The following is a description of a gene set: species: Homo sapiens Bulbar signs Human Gene Set: HP_BULBAR_SIGNS, and this is the list of marker genes: MT-TV, ATXN1, MT-ND3, CACNA1A, MT-TL1, PSAP, MT-TW, GFAP, SLC1A3, RYR1, MT-ND1, ARSA, MT-ATP6, MT-ND6, SPTLC1, ACTA1, MYPN, KBTBD13, GSN, PLAA, ATP1A3, NEB, FIG4, VAPB, SIGMAR1 (NCBI Gene Id 80768, sigma non-opioid intracellular receptor 1), SPG11, MT-ND4, TPM2, TFG, TPM3, PLA2G6, MT-TK, CHCHD10, GBA1, FUS, REEP1, ALS2, SLC39A14, NEK1, ATP1A2, MT-ND2, MATR3, MT-ND5, KLHL41